Given this list of marker genes Snca, Htr2c, Atp2b4, Comt, Itgam, Atp7a, here is a description of the gene set: Any process that stops, prevents, or reduces the frequency, rate or extent of the chemical reactions and pathways involving amines. Mouse Gene Set: GOBP_NEGATIVE_REGULATION_OF_AMINE_METABOLIC_PROCESS studied in species Mus musculus